The following is a description of a gene set: species: Mus musculus A process that modulates the length of a microvillus. Mouse Gene Set: GOBP_REGULATION_OF_MICROVILLUS_LENGTH, and this is the list of marker genes: Ush1c, Vil1, Twf2, Ezr, Cdhr5, Cdhr2, Pls1